The following is a description of a gene set: species: Homo sapiens Genes upregulated in subsets of cells of a given type within various tumors Human Gene Set: GAVISH_3CA_METAPROGRAM_EPITHELIAL_PDAC_RELATED_2 In this study, an extensive analysis was conducted to define meta-programs (MPs) capturing intra-tumor heterogeneity across a spectrum of tumor types. The approach utilized non-negative matrix factorization (NMF) to analyze each cell type separately within individual tumor samples. This involved the analysis of malignant cells, macrophages, fibroblasts, endothelial cells, epithelial cells, T-cells, and B-cells. NMF was executed with varying parameter values (K=4, 5, 6, 7, 8, 9), thereby generating 39 programs for each cell type per sample. Each NMF program was summarized by the top genes based on NMF coefficients.\nRobust MPs were then delineated for each cell type using a set of stringent criteria, including recurrence within the same tumor, similarity to programs in other tumors, and non-redundancy within a tumor. Subsequently, these robust NMF programs were clustered (per cell type) based on Jaccard similarity, leading to the identification of MPs associated with each cell type.\nTo enhance the quality of the MPs, a refinement steps were undertaken, involving the removal of MPs suspected of reflecting low-quality data (with an overrepresentation of ribosomal proteins or mitochondrial-encoded genes), single-study inclusion, or similarity to miss-annotated cell types. from publication Gavish A, Tyler M, Greenwald AC, Hoefflin R, Simkin D, Tschernichovsky R, Galili Darnell N, Somech E, Barbolin C, Antman T, Kovarsky D, Barrett T, Gonzalez Castro LN, Halder D, Chanoch-Myers R, Laffy J, Mints M, Wider A, Tal R, Spitzer A, Hara T, Raitses-Gurevich M, Stossel C, Golan T, Tirosh A, Suvà ML, Puram SV, Tirosh I (PMID 37258682), and this is the list of marker genes: PHGR1, CEACAM5, MUC5AC, GPRC5A (G protein-coupled receptor class C group 5 member A), PDZK1IP1, S100P, MMP7, CLDN23, CEACAM6, IFI6, ISG20, MUCL3, LAMC2, TRIM29, CLIC3, DHRS9, SLC2A1, DUOX2, PLAUR, C15orf48, ITGA2, EPS8L1, KLK10, COL17A1, TIMP1, SLPI (secretory leukocyte peptidase inhibitor), IL32, CTSE, TACSTD2, DUOXA2, SLC6A14, REG4, APOL1, PI3, KRT7, MALL, KRT19, S100A4, LMO7, TFF1, CD55, ANXA1, TFF3, MUC1 (NCBI Gene Id 4582), TSPAN1, ERO1A, PLAC8, PSCA, PLAT, F3